Given this list of marker genes Tnp1, Smarcc2, Smarcd3, Smarcb1, Arid1a, Smarcd1, Supt16, Rpl23, Atad2b, Ssrp1, Myc, Smarca4, Smarcd2 (SWI/SNF related, matrix associated, actin dependent regulator of chromatin, subfamily d, member 2), Smarcc1, H2ac25, Arid2 (AT-rich interaction domain 2), Bmyc (brain expressed myelocytomatosis oncogene), Grwd1, Atad2, H2bc1, Cebpg, Smarce1, here is a description of the gene set: Mouse Gene Set: GOBP_PROTEIN_DNA_COMPLEX_DISASSEMBLY The disaggregation of a protein-DNA complex into its constituent components. species: Mus musculus